The following is a description of a gene set: Genes up-regulated in comparison of dendritic cells (DC) stimulated with LPS (TLR4 agonist) at 12 h versus DC cells stimulated with CpG DNA (TLR9 agonist) at 12 h. from publication Amit I, Garber M, Chevrier N, Leite AP, Donner Y, Eisenhaure T, Guttman M, Grenier JK, Li W, Zuk O, Schubert LA, Birditt B, Shay T, Goren A, Zhang X, Smith Z, Deering R, McDonald RC, Cabili M, Bernstein BE, Rinn JL, Meissner A, Root DE, Hacohen N, Regev A (PMID 19729616) Human Gene Set: GSE17721_LPS_VS_CPG_12H_BMDC_UP studied in species Homo sapiens mouse primary BMDCs were stimulated with tlr ligands and gene expression changes were profiled on Affymetrix arrays, and this is the list of marker genes: MPP2, FCHO1, ACYP2 (NCBI Gene Id 98), GBP6, CSF1, CACNB4, SERPINB9, LZTR1 (leucine zipper like post translational regulator 1), WDPCP, CXCL10, GUCD1 (guanylyl cyclase domain containing 1), INSL6, TMEM30A, PENK, SELENOK, ANAPC13, HMGXB4, ECE1, SEC24D, BRD4, ZNHIT1, DENND5A, GUK1, ISOC1, MEP1A, KLHL36, DCTN3, GFI1, RO60, LAPTM4B, SAMHD1, ACTB, BIRC2, SP110, TMEM63B (NCBI Gene Id 55362), SNX10, ERBIN, PDIA5, TIMELESS (timeless circadian regulator), CAPRIN1, CPNE2, CD80, STRA8, HELZ2, HDAC1, ZNF574, HNF4G, MSANTD3, CRBN, PML, GRINA, PON3, IL15, APOOL, KRT12, CXCL9, APC, FAM20B, AK4, PLAT, IL1RN, TGFBR2, LRRC8C, CASP4 (caspase 4), DOK1, LRP4, URI1, STING1, SF3A1, TENT2, SLC6A4, UQCC3, FOXJ3, MISP, TAPBPL, C8orf33, SLC38A5, NDUFS3, BAP1, TMTC4, COPS7A, PSIP1, VCAM1, VIPR2, GRAMD4, PRPF38A, TRRAP, APOA2, DNAJA2, HSPA1B, SLCO3A1, TCF4, POLR2G, CD86, ITGA2B, TMEM243, F13B, SERPINE1, PHC2, ARFGEF1, GPATCH8, ELOC (elongin C), DCAF5, TNFSF10, UBL5, MAN2A1, IFIT2, FAAP20 (FA core complex associated protein 20), AHCYL2, CD83, BLTP1, ITGA4, PLAC8, AQP8, GLCCI1, POLB (NCBI Gene Id 5423), IL15RA, NT5C3A, UBE2R2 (NCBI Gene Id 54926), CMPK1 (NCBI Gene Id 51727), IL23A, SIX1, TSPAN33, TPX2, H6PD, BMI1, HEMK1, RAB21, RB1, ARF5, TNFSF8, SPAG4, RAB22A, FHOD3 (formin homology 2 domain containing 3), COMMD7, PLAGL2, MTRES1, GALNT10, CPNE3, HOXA11, CDKN1B, SLC1A2, PTK6, GAD2, TRIM21, TBXA2R, WDFY1, ALDH1A2, TAOK1, NCOA3, RTF2, YTHDF1, IL21R, TIMP1, UPP1, OGFR, ARID5A, SGTB, VWA5A, DDB2, ACOD1, CHAC2, GYPC, RREB1, UAP1, SYN1, IFIT3, TLR3, TSHZ1, PDLIM5, ABCA2, IL7R, EPS8L2, PTEN, SOX11, MOV10, BATF2, FRYL, NECTIN2, FEM1B, SEH1L, NRIP1, DOLK, KEAP1, SEC24B, TOMM70, USP48, LTA, HMGN3 (NCBI Gene Id 9324), PFKP, EXOC7, MNX1, SAMSN1, MACROH2A1, TPST1, COX4I1, KIF16B, PXMP2, BAG3